Given this list of marker genes RECK, ATP6V0A2 (NCBI Gene Id 7854), ADAMTSL4, WBP1, SIGMAR1, EYA3, UVSSA, TAX1BP1, IGLC7, POLR3D, PSMB4, HMOX2 (NCBI Gene Id 3163), LDLRAP1, HSPB6, PRELID1, HSP90B1, RCHY1, CRBN, CANX, LMAN2, RPL36A, TMED9, CACNB3, SLC16A10, RDH10 (retinol dehydrogenase 10), RASA3, RIPPLY3, UBE2E3, PPT2, PRICKLE3, NUDT17, EFNA2, DUSP12, S1PR4, PON2, ATP6AP1, MAP3K7, ALG1, FBXO17, RTN3, SPSB1, NPC1, MIA2, KIF5C, GOLGA5, PGRMC1, GSTM3, TNFRSF4, FKBP1B, SARS1, GBP4, KLHL25, ECSCR, ZNF260, AHCYL2, GPR108, PABIR1, MTAP, ACBD5, BPGM, SLC7A11 (NCBI Gene Id 23657), RAPH1, ZDHHC12, CACNA1E, PRDX6, CNNM2, HSD17B11, RNF5, B3GALT5, TMEM50A, AUP1, KHK, MGAT4A, APPL1, MFSD6L, TBRG1, HADHB, MARK3, SPOP, PRPF39, LZTFL1, HAX1, RNF181, STUB1, RBIS, KREMEN1, CHD2, XKR8, COX17, IL6R, RIPOR1, SLC39A4, ETV3, TMEM184B, ZSCAN25, PROCR, FKBP2, ABHD17B, CDC123, STK38L, UBE4A, SLC1A4, VTI1A, P2RY14, CCDC146, UBXN8, ARHGAP1, SEZ6L, UXS1, DYRK3, ALG14, TM9SF2, PTPRE, SPO11, ADIPOR1, FLOT1, SAYSD1, SAMHD1, SIPA1L3, C8orf34, HGSNAT, DYM, ENTPD4, RASA4, TMX1, CITED2, MLX, UGGT1, SYS1, TBL2, ARSG, THAP7, MMGT1, RIOK3, GNL3, MRPS28, TIMM21, SLCO4A1, SLC50A1, PELO, RAB2A, ALPK2, LAMB2, AKR1B15, DCTN6, HERPUD1, ATF6B, NAT9, GSDMD, TAPBPL, SLC22A23, NHERF2, BSCL2, EXOC6B, MGAT1, NDUFB6, EHBP1, SS18L2, GOLGA3, SERPINB8, VAMP4, SND1, MAB21L3, UBALD2, PXN, EEF1D, CORO2B, EDF1, SHISA5, NFIC, HBS1L, EAF2, ATG9A, FBXO38, SLC35C2, DGKD, IL13RA1, POGLUT2, MAPKAPK5, ATPSCKMT, IER2, CTBS, GOLGA2, SNUPN, P3H1, CTNNA1, MOSPD3, RAB33B, CCDC71L, SLC35C1, CSAD, GOSR2, ZNF652, ATP6AP2, CACNG6, IMPDH1, DPH3, ACER3, RNF123, DNAJC1, here is a description of the gene set: from publication Lund R, Aittokallio T, Nevalainen O, Lahesmaa R (PMID 14607935) species: Homo sapiens Th1 and Th2 cells arise from a common precursor cell in response to triggering through the TCR and cytokine receptors for IL-12 or IL-4. This leads to activation of complex signaling pathways, which are not known in detail. Disturbances in the balance between type 1 and type 2 responses can lead to certain immune-mediated diseases. Thus, it is important to understand how Th1 and Th2 cells are generated. To clarify the mechanisms as to how IL-12 and IL-4 induce Th1 and Th2 differentiation and how TGF-beta can inhibit this process, we have used oligonucleotide arrays to examine the early polarization of Th1 and Th2 cells in the presence and absence of TGF-beta after 0, 2, 6 and 48 hours of polarization. Human Gene Set: GSE2770_IL12_ACT_VS_ACT_CD4_TCELL_48H_UP Genes up-regulated in CD4 T cells activated by anti-CD3 and anti-CD28: IL-12 (48h) versus untreated (48h).